Given this list of marker genes CPSF4L, ENTPD1, TXNRD2, EEF1AKMT1, WDFY2, CHURC1, SDHD, ATMIN, QTRT1, CERK, NCBP1, ZNF706, FOXO3 (NCBI Gene Id 2309), ALDOA, BUB1B, PAICS (phosphoribosylaminoimidazole carboxylase and phosphoribosylaminoimidazolesuccinocarboxamide synthase), GPX4, NFIL3, NSMCE4A, GLUD1, SIL1, ATP5F1A, GRM1 (NCBI Gene Id 2911), ENO3, BTK, PRKAG2, DRAP1, TRAPPC12 (trafficking protein particle complex subunit 12), FAM89B, EXOC6, CTNNBIP1, NDUFS3, RAP1A, DAD1 (defender against cell death 1), VTI1B, RPL22, FBXL6, POLD1, AAMP, ZFP36L2, BANF1, DPH5, NNT, NTRK3, MVK, KLHL9, RASGRP4, SH2D1B, DNAJC3, LIPA, DNAJC5, GTF2F1, NMB, RPS18, SLC66A2, NUDT2, ECHS1, UBR7, TBL1XR1, MACROH2A1, PARVG, IPP, EIF3I, S100A1, NIPSNAP1, APCDD1, DDT, SS18, PKIB, GM2A, ITFG1, COQ5, TIAM2, ADAMTS10 (NCBI Gene Id 81794), MNT, GBF1, FMO3, MCOLN3, HEXB, AP1G2, SIRT7, STK11IP, CLEC7A, IRF2, OXA1L, ZNF358, SNRPD2, TSPAN14, SARS1, IMPDH2, PNPO, OAF, TMEM141, KCTD12, TMEM176B, RECQL, ID1, TNFRSF9, TCTE1, ANAPC5, IL4R, SLC7A5, B4GALT6, ACO2, MCUB, DPCD (NCBI Gene Id 25911), KCNN4, PMM1, MRPL48, PYCR2, CISD1, POLE3, FNBP1, RAP2B, STOM, TOM1, MTX2, ADIPOR2, DDB1, NXN, SPTBN1, FANCL, SNX3, GNL3, NUP37, HACD4, LPCAT1, PHKA2, ESR2, MMUT, BRMS1, MPO, SELENOH, HIGD1C, RRAS2, BLTP2, S100A13, CDK5RAP3, AGGF1, CSNK1G2, CTDNEP1, RPS6KA1, ZSCAN12, PHPT1, EXTL2, IL21, NDUFS6, CDKN1A, DBNL, LSR, CPSF3, ASL, TRMT1, PRMT7, CDCA5, BLVRA, EWSR1, ARHGEF25, YBX3, CAD, POLR3GL, KIF20A, TNFRSF12A, CD8B, PPP1R14B, CTCF, GFM1, CNPY2, NDUFAF1, TMEM234, PTGER4, HSF2, MAP2K3, PIGO, PBDC1, FMC1, HMBS, KLK8, FRRS1, RAD54L2, MANSC1, HMGB1, SEPTIN11, DNAJC8, BBS2, SLC39A1 (NCBI Gene Id 96436), EXOSC8, COPRS, XPC, PPP2R3A, CERS4, MPHOSPH6, EGLN3, SERPINB1, RPS6, ARHGAP1, TJP2, IDH3B, RALBP1, NREP, here is a description of the gene set: Genes up-regulated in comparison of dendritic cells (DC) stimulated with Gardiquimod (TLR7 agonist) at 0.5 h versus those stimulated with Gardiquimod (TLR7 agonist) at 12 h. mouse primary BMDCs were stimulated with tlr ligands and gene expression changes were profiled on Affymetrix arrays species: Homo sapiens from publication Amit I, Garber M, Chevrier N, Leite AP, Donner Y, Eisenhaure T, Guttman M, Grenier JK, Li W, Zuk O, Schubert LA, Birditt B, Shay T, Goren A, Zhang X, Smith Z, Deering R, McDonald RC, Cabili M, Bernstein BE, Rinn JL, Meissner A, Root DE, Hacohen N, Regev A (PMID 19729616) Human Gene Set: GSE17721_0.5H_VS_12H_GARDIQUIMOD_BMDC_UP